The following is a description of a gene set: Mouse Gene Set: CUI_MACROPHAGE_IFNB_RESPONSE_DN Cytokines mediate cell-cell communication in the immune system and represent important therapeutic targets. A myriad of studies have highlighted their central role in immune function, yet we lack a global view of the cellular responses of each immune cell type to each cytokine. To address this gap, the authors created the Immune Dictionary, a compendium of single-cell transcriptomic profiles of more than 17 immune cell types in response to each of 86 cytokines (>1,400 cytokine-cell type combinations) in mouse lymph nodes in vivo. A cytokine-centric view of the dictionary revealed that most cytokines induce highly cell-type-specific responses. For example, the inflammatory cytokine interleukin-1β induces distinct gene programmes in almost every cell type. A cell-type-centric view of the dictionary identified more than 66 cytokine-driven cellular polarization states across immune cell types, including previously uncharacterized states such as an interleukin-18-induced polyfunctional natural killer cell state. from publication Cui A, Huang T, Li S, Ma A, Pérez JL, Sander C, Keskin DB, Wu CJ, Fraenkel E, Hacohen N (PMID 38057668) species: Mus musculus Genes negatively differentially expressed in cell type: Macrophage upon treatment with cytokine: IFN-β in mouse lymph nodes in vivo., and this is the list of marker genes: Sdhaf1, Tle5, Eef1a1, Vamp5, Tbc1d14, Ppp2r5c, Gna12, Mafb, Ftl1 (ferritin light polypeptide 1), Rack1, Calm2, Tkt, Naca, Gpx1, Cox7a2l